The following is a description of a gene set: Human Gene Set: GSE44955_MCSF_VS_MCSF_AND_IL27_STIM_MACROPHAGE_UP In this study, we hypothesized that IL-27 could induce the expression of novel miRNAs in macrophages which may have functional relevance in terms of anti-viral activity. In this study, primary monocytes were differentiated into macrophages using M-CSF (M-Mac) or with a combination of M-CSF and IL-27 (I-Mac) for seven days. Following this, total RNA was extracted from these cells and deep sequencing was performed, in parallel with gene expression microarrays. Using the novel miRNA discovery software, miRDeep, seven novel miRNAs were discovered in the macrophages, four of which were expressed higher in I-Mac (miRNAs 2.1, 8.1, 9.1 and 14.2) whilst three were detected in both M-Mac and I-Mac (miRNAs 9.3, 13.6 and 15.8). The expression of six of the seven novel miRNAs was highly correlated with qRT-PCR using specific primer/probes designed for the novel miRNAs. Gene expression microarray further demonstrated that a number of genes were potentially targeted by these differentially expressed novel miRNAs. Genes up-regulated in macrophage differentiated by: CSF1 versus CSF1 and IL27. from publication Swaminathan S, Hu X, Zheng X, Kriga Y, Shetty J, Zhao Y, Stephens R, Tran B, Baseler MW, Yang J, Lempicki RA, Huang D, Lane HC, Imamichi T (PMID 23535375) studied in species Homo sapiens, and this is the list of marker genes: MRPS18A, CD300LF, APOBEC3G, OMA1, ABHD6, HIVEP2, GUSB, KCNJ5-AS1, TTLL4, PSME2, CD300A, OLR1, HNRNPA1L2, MRPS31, SLC1A4, GPR132, RAD51AP1, IQCK, IL6ST, DVL3, TAGLN2, APLP2, SNN, ZBTB7C, MMD, TIAM2, NHERF1, IRAK1, METTL1, RAB20, DNAJB11, DSP, CDKN1A, CYP27A1, IL22RA2, RHBDF2, UCK2, MCM2, NPC2, CD300LB, NUB1, EIF1B, TMEM230, SERPINE2, FGGY, TGM2, LAIR1, CFAP68, NDUFB3, CFAP184, FGR, R3HDM2, SLC36A4, ZNF22, NRIP1, MAN1A1, ANKRD29, SRA1, TMEM268 (transmembrane protein 268), FECH, TESK1, TRIM6, F3, SAT1, LCMT2, DOK3, BCL7B, AVEN, AHI1, CIB1, DYNLT1, RIPK2, ENDOD1, CNNM4 (cyclin and CBS domain divalent metal cation transport mediator 4), STON2, LMAN2L, DOCK5, IL1B, RCN1, CCT2, LONP1, ATP6V1G1, IRF1, EHBP1L1, CCL2, TMEM52B, SPIN4, CYSLTR1, THEM4, CHCHD4, NANP, SLC9A3-OT1, DERL2, CD72, PLA2G5, ENOSF1, CYB561A3, SPMIP1, CHST15, MELTF, MLKL, GALM, TLNRD1, TBC1D1, ZWILCH, MTMR14, ZMYND15, PRKCB, EEF1B2, ELOC, POR, LMNB1, HLA-DPB2, SEC61G, SEL1L3, SNTB1, PTS, AGPAT4, SIPA1L2, PCCA, FILNC1, C3, RGS12, PPFIBP2, C1RL, SYNJ2, GFOD1, USP11, ACSL1, SLC7A5, CASTOR3P, TBC1D2, TIMP1, BST1, CD55, IL18, STX18, THBS3, RND3, RPS11, FAM117A, NRIP3, UPP1, RHOBTB3, PDE6D, GBP4, CYBB, RFLNB, ABHD2, CCL5, ST20-AS1, ST20, GTF2E2, CD1D, PRAM1, PDGFB, TIE1, N4BP2L1, TSPAN13, AFAP1, ECD, NXT1, SMIM20, HYOU1, NDUFB9, FAM20C, NDUFA2, TMCC3, TBL2, ATP6V1E1, AIMP2, ZNHIT3, SDSL, POGLUT1, CR1, TNFRSF1B, IKBKE, MYO1F, BPI, FXYD6, TNFAIP2, PRDX6, RNASEK, ASB2, KGD4, LRRC32, DPY19L3, TMEM138 (transmembrane protein 138), NME1, TRAFD1, AMPD3, SIGLEC17P, CNPY2 (canopy FGF signaling regulator 2), EML4, FKBP15 (NCBI Gene Id 23307), HLA-DMB, MRAS, IDO1